The following is a description of a gene set: species: Homo sapiens A renal system process in which water, ions, glucose and proteins are taken up from the collecting ducts, glomerulus and proximal and distal loops of the nephron. In non-mammalian species, absorption may occur in related structures (e.g. protein absorption is observed in nephrocytes in Drosophila, see ). Human Gene Set: GOBP_RENAL_ABSORPTION, and this is the list of marker genes: HAS2, SLC12A3, KLHL3, NHERF1, AMN, CD2AP, CLDN19, AKR1C3, CLDN4, WNK4, EDN1, EDNRA, SLC6A18, GUCA2B, MLLT6, GSN, HNF1A, SLC15A2, KCNJ1, HBB, CLCNKB, OXSR1, CLDN16, SLC5A1, EDNRB, GAS6, ADIPOQ, HYAL2, AQP3, CLCNKA, MAGED2, UMOD, STK39, AQP1, KCNQ1, SGK1, KIRREL1, WNK3, SLC5A2, COMT